Given this list of marker genes RASAL3, FBP1, RASA4, LZTR1, STAMBP, RASA2, RASA4B, RASA3, TRIM67 (tripartite motif containing 67), SYNGAP1, SPRY2, SPRY4, SPRY1, MAPKAP1, NF1 (NCBI Gene Id 646021), EPHB2 (EPH receptor B2), NUP62, MFN2, DAB2IP, RABGEF1, SPRY3, TGFB2, PPP2CB, RASAL1, here is a description of the gene set: Human Gene Set: GOBP_NEGATIVE_REGULATION_OF_RAS_PROTEIN_SIGNAL_TRANSDUCTION Any process that stops, prevents, or reduces the frequency, rate or extent of Ras protein signal transduction. studied in species Homo sapiens